Given this list of marker genes ST8SIA3, TNFSF11, ASIC4, KCNK2, ANXA5, RGS6, RBM39, RAD54L2, BSN, CCNA2, ATG14, RHOXF1, NSD2, ZNF737, PRKCA, EXOC6B, FAT3, MRC2, FNDC3A, PMPCB, ANKH, KPNA3, ADCYAP1, ATP6V1F (NCBI Gene Id 9296), MAGI1, MYRIP, KIR3DL3, CCL4L2, COBLL1 (cordon-bleu WH2 repeat protein like 1), CAV3, NRP2, ZBTB33, DPY30, ECHDC1, BRWD1, AS3MT, DIPK1A, DCUN1D4, TIA1, RAP1A, PPARGC1B, SLC26A7, SEL1L, TMX2, NIPA1, SPRY2, GLIS3 (GLIS family zinc finger 3), DCAF5, EFNA5, FUT11, CCDC115, OGA, TOP1, CDH8, CD2AP, DMRT2, NUFIP2, MON2 (MON2 homolog, regulator of endosome-to-Golgi trafficking), SLC30A10, KCNA6, ATXN3, RABGAP1, VCF1, HJV, EMX2, COL12A1, PALM2AKAP2, TRAK2, KLHDC8A, SLITRK4, BRF2, TSC1, LINGO2, TMEM178B, TMEM215, HAPSTR2, PNPLA4, CXCR6, CDK14, SLC24A2, RMND5A, KLHL29, ADRA1A, WDR1, ANK3, here is a description of the gene set: Human Gene Set: MIR6781_3P Genes predicted to be targets of miRBase v22 microRNA hsa-miR-6781-3p in miRDB v6.0 with MirTarget v4 prediction scores > 80 (high confidence targets). species: Homo sapiens from publication Chen Y, Wang X (PMID 31504780)